The following is a description of a gene set: Human Gene Set: WP_NSP1_FROM_SARSCOV2_INHIBITS_TRANSLATION_INITIATION_IN_THE_HOST_CELL studied in species Homo sapiens nsp1 from SARS-CoV-2 inhibits translation initiation in the host cell, and this is the list of marker genes: EIF3H, EIF3A, EIF3J, EIF3G, EIF3C, EIF2S1, EIF5, EIF3B, EIF1AX, EIF1, EIF3D, EIF3E, EIF2S3, EIF2S2, EIF3F, EIF3I